Given this list of marker genes CASR, CALM2, ASPH, CALM3, SYT1, KCNMB3, CASQ2, CALM1, KCNIP2, KCNMB1, STIM1, RYR2, KCNMB4, KCNMB2, here is a description of the gene set: Human Gene Set: GOBP_DETECTION_OF_CALCIUM_ION The series of events in which a calcium ion stimulus is received by a cell and converted into a molecular signal. species: Homo sapiens